Given this list of marker genes EXOSC9, EXOSC3, ELAC2, EXOSC7, TRDMT1, RNH1, EXOSC2, EXOSC8, POP1, ANG, EXOSC10, TRNT1, SLFN13, METTL1, NSUN2, ZCCHC7, DICER1, here is a description of the gene set: The chemical reactions and pathways resulting in the breakdown of tRNA, transfer RNA, a class of relatively small RNA molecules responsible for mediating the insertion of amino acids into the sequence of nascent polypeptide chains during protein synthesis. studied in species Homo sapiens Human Gene Set: GOBP_TRNA_DECAY